Given this list of marker genes UBQLN4, CLN3, ATG5, TECPR1, PHF23, CLEC16A, CALCOCO2, ATG12, ADRB2, FYCO1, TBC1D25, TOM1 (NCBI Gene Id 10043), RUBCN (NCBI Gene Id 9711), SMCR8, UVRAG (UV radiation resistance associated), TMEM39A, IRGM, here is a description of the gene set: Human Gene Set: GOBP_REGULATION_OF_AUTOPHAGOSOME_MATURATION studied in species Homo sapiens Any process that modulates the frequency, rate or extent of autophagosome maturation.